Given this list of marker genes EDN1, EDNRA, TWIST1, JAG1, ENG, HES1 (hes family bHLH transcription factor 1), BMP4, SEMA3C, HAND2, BMP7, PITX2, FOLR1, CDC42, here is a description of the gene set: studied in species Homo sapiens Human Gene Set: GOBP_CARDIAC_NEURAL_CREST_CELL_DEVELOPMENT_INVOLVED_IN_OUTFLOW_TRACT_MORPHOGENESIS The process aimed at the progression of a cardiac neural crest cell over time, from initial commitment of the cell to its specific fate, to the fully functional differentiated cell that contributes to the shaping of the outflow tract.